The following is a description of a gene set: studied in species Homo sapiens Human Gene Set: GOMF_S100_PROTEIN_BINDING Binding to a S100 protein. S100 is a small calcium and zinc binding protein produced in astrocytes that is implicated in Alzheimer's disease, Down Syndrome and ALS., and this is the list of marker genes: EZR, S100A6, ANXA2, AGER, S100B, CACYBP, FGF1 (fibroblast growth factor 1), ANXA11, ATP2A2, S100A11 (NCBI Gene Id 6282), S100A1, IQGAP1, KCNK3, AHNAK